The following is a description of a gene set: studied in species Homo sapiens PDGFR-beta signaling pathway from publication Schaefer CF, Anthony K, Krupa S, Buchoff J, Day M, Hannay T, Buetow KH (PMID 18832364) Human Gene Set: PID_PDGFRB_PATHWAY, and this is the list of marker genes: ITGAV, PRKCA, DNM2, PIK3R1, ARPC5, ARPC3, WASL (WASP like actin nucleation promoting factor), FYN, LRP1, PPP2R2B, SFN, RAB5A, RPS6KA3, SIPA1, CBL, ARAP1, ABI1, MAPK10, ARHGAP35, RAC1 (NCBI Gene Id 5879), PLCG1, HCK, NCKAP1, ARHGDIA, MAP2K4, JUND, VAV2, FOS, GRB10, MAPK3, MAP2K2, FGR, EIF2AK2, STAT5B, DOCK4, PRKCE, ARPC2, PTPN1, PTPRJ, RAF1, BLK, PTPN11, PIN1, PLA2G4A (phospholipase A2 group IVA), RAB4A, RAPGEF1, JUN, MAP2K1, NRAS, S1PR1, PIK3R6, SLA, ACTR2, PIK3CG, PDGFB, PIK3CA, PDGFRB, PPP2CA, ACTA2 (NCBI Gene Id 59), BCAR1, YWHAG, KSR1, BAIAP2, CTTN, ELK1, RHOA, MAPK1, ACTR3, YWHAB, RAP1A (RAP1A, member of RAS oncogene family), WASF2, RASA1, MAPK9, AFDN, YWHAH, CSK, MAP2K7, PIK3CB, CRK, EPS8, NHERF1, MYOCD, PRKCD, BRAF, STAT3, YWHAE, ABL1, PPP2R1A, SHC1, ARPC1B, STAT5A, GRB2, SPHK1, NHERF2, PIK3R3, ARPC4, PIK3CD, IQGAP1, GAB1, YWHAZ, SRC, BRK1, YWHAQ, LCK, YES1, NCK2, ITGB3, PAK1, MAPK8, CYFIP2, MYC, KRAS, STAT1, JAK2, PTPN2, PAG1, HRAS, LYN, PIK3R5, NCK1, DOK1, RAP1B, PIK3R2, PTEN, USP6NL, SOS1, ACTN4, TAGLN, SRF